Given this list of marker genes ELANE, CXCR2, TLR7, TET2, FOXN1, DOCK8, BCL11A, HYOU1, TAP2, MECP2, CD28, CD3D, PIK3R1, IGHG2, NFKBIA, REL, TLR3, IL7, BLM, SASH3, ADORA2A, TRAF3, CD40LG, CD247, MCM10, TICAM1, IL2RB, ISG15, XIAP, KLF1, UNC93B1, ZNFX1, TRAC, TMC8, NCKAP1L, STAT2, IRF7, CD3E, IRF3, HBB, MAGT1, TPP2 (NCBI Gene Id 7174), TOM1, SNORA31, RAG2, DOCK2, STK4, IKBKG, TBK1, RAG1, TNFRSF9, PRPS1, IGKC, HBG1, CD27, CD70, SH2D1A, RFXANK, PGM3, ITK, DNASE2, DEF6, TGFB1, CTPS1, FCGR3A, IL7R, CARD11, PIK3CD, PRKCD, STAT1, FCGR3B, IKZF3, PTEN, LAT, RAC2, IL2RA, HBG2, DBR1, FOXP3, here is a description of the gene set: Human Gene Set: HP_SEVERE_INFECTION studied in species Homo sapiens Severe infection A type of infection that is regarded as a sign of a pathological susceptibility to infection because of unusual severity or intensity of the infection.